Given this list of marker genes VPS54, ADARB1, ERBB3, NEFL, SPG11, RHOA, ATF2, SLC1A1, MAP3K12, ROCK1, CRLF1, FADD, ZPR1, RAPSN, MAP2K7, CNTFR, KCNB1, MAP2K4, FAS, BCL2, BAX, here is a description of the gene set: Any apoptotic process in a motor neuron, an efferent neuron that passes from the central nervous system or a ganglion toward or to a muscle and conducts an impulse that causes movement. species: Homo sapiens Human Gene Set: GOBP_MOTOR_NEURON_APOPTOTIC_PROCESS